Given this list of marker genes ZNF281, ZDHHC15, LRRC17, ELOVL5, TMEM170B, FXR1, ATXN1, ABHD6, UNC5D, MAP3K1, STRIP1, PAIP1, TRAK1, ZNRF3, MANEA, GALNT2, TMED5, PPP6R3, TNKS2, SH3PXD2A, ADGRL3, RERG, MPZL2, SERPINB1, UPRT (uracil phosphoribosyltransferase homolog), OSBPL8, ITGAD, TRIO, POLR3G, IL5RA, SIKE1, CREBZF, NLGN1, TBRG1, SNX10, RAB21 (NCBI Gene Id 23011), TSHZ2, CAMK4, UNC80, SMC5, TMEM45A, CCDC43, EPHA5, PPARGC1B, CDKL3, SAMD8, MAN1A1, TLL2, FYN, LMO3, SLC38A4, HIF1A, LRCH2, PARD3B, ST8SIA1, SOCS1, ZDHHC21, ITGBL1, RC3H1, ZNF391, DNAAF9, DLG1, SUB1, CADM2, RNF145, LIN7A, ZNF451, MAPK8, TCAIM, ITGB1, SMURF1, ABRA, ITGB2 (NCBI Gene Id 3689), IPMK, MAN1A2 (mannosidase alpha class 1A member 2), BRD10, RGS7BP, ZMYM2, BLTP3A, RAB23 (RAB23, member RAS oncogene family), SFXN1, MED10, KAT2B, JPH1, RPS6KA5, PDZD8, KIAA1549L, EYA2, ORC3, EVI2B, AFTPH, ATRX, TNRC6B, ABHD13, SEC22C, DLD, PTPRK, LDAF1, BTC, CYRIA, SRGAP2, TOB2, PHC3, GLDC, ITGB8, RGS8 (NCBI Gene Id 85397), TMCC3, TCF7L2, UFD1, ALDH1L2, ZNF34, PATL1, HIPK1, NOTCH3, FABP7 (NCBI Gene Id 2173, fatty acid binding protein 7), MEF2C, TGFBR2, ETNK1, LYSMD3, FNIP1, DNAJA2, EYA1, DGKE, RAD54B, REST, XIAP, GFM2, WDR33, ZBTB24, EXTL2, CCDC102B, RSL24D1, MAPRE2, ENTPD3, RAP1B, NUDCD2, YME1L1, PALS2, ANKRD26, PPP4R2, MEGF9, MAP3K4, BORA, CAPN7, SUZ12, KCNB1, DDR2, TMEM236, PGAP1, CTCF, SMCO1, PMP22, KLHDC1, C6orf118, C11orf54, RUNDC3B, HOMER1, PEX5L, ATP11C, GABPA, PPP1R12A, NRBF2, INO80D, NUCKS1, HIPK3, CHL1, YPEL5, ELF1, SRSF7, CHIC1, HSPA13, ZFY, ASXL1, THSD7A, DUSP8, ZFX, LRAT, ZCCHC10, RABGEF1, C8orf34, ADAMTS7, SLC25A36, PHF6, MED30, CNTN4, MMAA, THAP1, C2orf69, RGPD1 (RANBP2 like and GRIP domain containing 1), KIF20B, ZNF711, TENM3, PIK3C2A, LRRTM2, PPM1B, CIP2A, STK26, GLUD1, TNFSF13B, PRKAA2, RANBP3L, BEND3, BCKDHB, SYT4, ANKRD17, CAB39, TMEM33, GPATCH2, WDR82, AVL9, PIEZO2, NETO2, ZEB2, CNTN3, COL25A1, PTN, KDM5C, CLGN, MAL2, MB21D2, MARCHF1, RBM47, B3GALT1, CUL4A, ARHGAP29, TVP23C, MIPOL1, MID2, DOK6 (NCBI Gene Id 220164), OLFM3, EFR3A, ABCE1, NCAN, AHR, CHM, SERPINB9, ARHGAP15, KLHL20, IKZF2, HAUS5, SCN2A, ZFP82, IRF4, PTER, SLC2A13, APP, ZBTB41, YTHDF3, SNX16, CSRP2, PICALM, STX2, ZFP28, PYROXD1, SLMAP, TRPS1, NHS, ZNF764, SEL1L3, NIPA2, MARK1, PPP3R1 (protein phosphatase 3 regulatory subunit B, alpha), NIPSNAP2, B2M, ZNF770, SPOCK3, CEBPG, SESTD1, HEATR5A, RAG1, NTNG1, LMNTD1, REPS1, TMTC4, JPH4, TBC1D8B, DZIP1L, FAM118B, UBE2D3, GUCY1A2, PHTF2, PCDH10, VPS36, ICMT, FSBP, RRAGC, ADM, UTRN, TDRD15, SLC4A10, GK2 (glycerol kinase 2), RERE, GRID2 (glutamate ionotropic receptor delta type subunit 2), SNX9, UFM1, EIF1AX, NMD3, STAU2, SMARCC2, VAT1L, SERPINB5, SRRM5 (NCBI Gene Id 100170229), CENPH (centromere protein H), AMFR, PSMF1, CLCC1, EDNRA, ZNF148, INTS13, HIC2, DIXDC1, ZNF484, ALG13, CAND1, LGALSL, PHF14, CPNE3, GALNT7, MAB21L1, SIX1, UQCC1, TAF1B, AVPR1A (NCBI Gene Id 552), DSC2, LARGE1, SIM1, SCN9A, SYNPO2, ELAVL2, DOCK3, KMT2C, DMGDH, PCDHB13, ZNF507, ZNF112, SLC7A11, ZBTB6, IMPACT, RASA2, SMURF2, ANAPC10, PM20D2, AK9, ARPC5, ENTPD1, RAB3GAP2, SCARA5, ZNF260, SUCLG2, GSKIP, RNF111, LSM1, PPM1N, ITGA1, AHI1, FHL5, EIF4A1, PTP4A1, PAWR, SERTAD2, ZNF585A (NCBI Gene Id 199704), FBXO33, MARCHF6, RTL3, KL, SAMD4A, SLC1A3, PLCH1, CCNT2, PRKAA1, PNPLA8, SOCS6, ZNHIT6, PARVA, FPR3, IL1RAPL2, SEC61A2, MOB3B, SLC12A6, NRF1, UGDH, RBM26 (RNA binding motif protein 26), TMCC1, TMEM181, RBAK, TRAPPC3, BCL2, CANX (calnexin), SEC24D, FAM161A, PTAR1, TK2, ZNF678, CPEB3, MTTP, CRPPA, FOXP2, SMG1, DGKH, SKIL, STOX2, MAP3K2, AKAP6, ACVR2A, GPR173, FRMD4A, BOD1L1, TFDP1 (NCBI Gene Id 7027), SATB2, RORA, GLRA2, BCAP29, TFAP2B, FAM218A, TRIM36, ERBIN, GNA13, TNC, RBM12B, NPM3, ACSF3, ZNF75A, SLC6A6, COPS2, HAPLN1, MORC1, OXR1, ZCWPW2, DYNC2H1, ORMDL1, SEMA3E, EIF5A2, LRRC7, HSPA4L, OBI1, BDP1, ADSS2, PLPPR4, CDK17, ADAMTS5, TENT4B, AZIN1, ZNF195, MAP3K20, PAX3, ATXN7, HECTD2, RRAS2, LRIT2, CLIP4, USP46, TNPO1, CLEC10A, HERC1, SEC23A, OPRM1 (NCBI Gene Id 4988), PLAGL1, LPAR1, TVP23B, CREM, RAB11FIP2, VGLL3, CDCA4, FHIP2A, XPO1, FCHO2, NR1D2, RANBP2, UBN2, ANP32B, SYAP1, PFDN4, PIAS2, C4orf19, FRMD4B, UBN1, STAM, RTKN2, RNF139, STEAP4, SPRYD7, LOX, SGIP1, here is a description of the gene set: Genes predicted to be targets of miRBase v22 microRNA hsa-miR-4495 in miRDB v6.0 with MirTarget v4 prediction scores > 80 (high confidence targets). from publication Chen Y, Wang X (PMID 31504780) Human Gene Set: MIR4495 studied in species Homo sapiens